Given this list of marker genes LTC4S, GSTM4, here is a description of the gene set: Reactome Pathway: Biosynthesis of DHA-derived sulfido conjugates studied in species Homo sapiens part of: Biosynthesis of DHA-derived SPMs The polyunsaturated fatty acid (PUFA) ω-3 docosahexaenoic acid (DHA) is a precursor for the production of novel sulfido-peptide conjugated mediators with structural similarity to the cysteinyl-leukotrienes and with novel biological properties. They are produced from specialised proresolving mediators (SPMs) in human macrophages and are termed protectin conjugates in tissue regeneration (PCTR), resolvin conjugates in tissue regeneration (RCTR), and maresin conjugates in tissue regeneration (MCTR) because they regulate mechanisms in inflammation resolution as well as tissue regeneration. Their biosynthesis is descibed in this section.